The following is a description of a gene set: species: Homo sapiens Severe short stature Human Gene Set: HP_SEVERE_SHORT_STATURE A severe degree of short stature, more than -4 SD from the mean corrected for age and sex., and this is the list of marker genes: GNPNAT1, ADAMTSL2, PIEZO2, PTH1R (NCBI Gene Id 5745), COX7B, LARP7, GHR, GLB1, COMP, POLE, COL2A1, RPL13, PYCR1, HCCS, IGF1R, ORC1, FLNB (filamin B), CDT1, GH1, GMNN, FGFR1, KIF11, NSMCE2, CTSA, SDHA, ERCC4, DLL3, ERCC6, NIN, MBTPS2, GHRHR, ERCC8, FAM111A, SDHAF1, CANT1, SGMS2, SLC26A2, AMER1, MESP2, CENPJ, PTDSS1, DDRGK1, SHOX, CDC45 (cell division cycle 45), PTCD3, IDS, SMAD4, ESCO2, DVL1, SIL1, ATP11A, FGFR3 (NCBI Gene Id 55546), TCTN3, HSPA9, PEX7, GUSB, DHCR24, MAP3K7, FBN1, GORAB, RMRP, KAT6B, COL1A1, TBX6, ORC4, B3GALT6, DVL3, STAT5B, KDM6A, NEPRO, SMARCA2, TRIP11, PIK3R1, DLX5, RNU4ATAC, ORC6, PNPLA6, BRF1, CENPT, COL1A2, RECQL4 (NCBI Gene Id 9401), FZD2, ADAMTS2, DNMT3A, NDUFB11, HSPG2, CKAP2L, TRPV4, INPPL1, ANTXR2, LYSET, CDC6, SALL4, LTBP3, RTTN, SDHD, DYM (NCBI Gene Id 54808), EPRS1, CSGALNACT1, STRA6, CRIPT, WNT5A (Wnt family member 5A), XYLT1, KMT2D, SDHB, HHAT (hedgehog acyltransferase), OBSL1, ANTXR1, PCYT1A